Given this list of marker genes Nsun2, Slfn8, Exosc3, Exosc2, Ang, Slfn9, Exosc9, Exosc8, Slfn2, Pop1, Exosc10, Exosc7, Trnt1, Mettl1, Trdmt1, Zcchc7, here is a description of the gene set: species: Mus musculus The chemical reactions and pathways resulting in the breakdown of tRNA, transfer RNA, a class of relatively small RNA molecules responsible for mediating the insertion of amino acids into the sequence of nascent polypeptide chains during protein synthesis. Mouse Gene Set: GOBP_TRNA_DECAY